Given this list of marker genes CR2, MGAT2, CD79B, MEIS2, IL7R, BLNK, RAG1, SLC39A7 (NCBI Gene Id 7922), ARPC5, CHD7, POLE, ACP5, IL2RG, CD3G, LAT, LRBA, SMARCAL1, BRAF, RTEL1, ADA, HBB, MAGT1, IKZF1, MBTPS2, MLPH, RNF31, IFNGR1, TBX1, FCGR3A, MTHFD1 (NCBI Gene Id 4522), PSMB10, PRKDC, RBCK1 (NCBI Gene Id 10616), PGM3, CTPS1, TICAM1, CTC1, FGFRL1, PTEN, PRPS1, GATA2, POGZ, BUB1B, ICOS, TNFRSF4, IRF7, HIRA, IL2RB, PIK3CA, TERC, RNF168, TP53, SKIC3, HYOU1, CD3E, SLC46A1, UNC119 (unc-119 lipid binding chaperone), SDHC, SH2D1A, TNFRSF1B, TYMS, SPI1, IRF2BP2, PIK3R1, DNMT3B, USB1, RAG2, MCM10, LRRC8A (leucine rich repeat containing 8 VRAC subunit A), OTULIN, SEC23B, EPG5, IKBKB, TINF2, CD79A, MS4A1, IGHM, TLR3, USP8, TBCE, CD19, LAMTOR2, WIPF1, IL2RA, CYBB, CD28, RREB1, TRAF3, NHEJ1, TCF3, CDCA7, UHRF1, STAT1, ORAI1, TNFRSF13C, PSTPIP1, CYBA, STK4, ATM, STIM1, LCP2, MAPK1, IFNGR2, MYC, ZBTB24, SP110, PI4KA, BCR, SBDS, SKIC2, NFE2L2, IL12B, CRKL, JMJD1C (jumonji domain containing 1C), DPP9, TYK2, HELLS, DKC1, RAB27A, CD81, DOCK2, ACD, ANTXR2, WRAP53, CDC42, LCK, AMN, IGLL1, SIK3, CUBN, DNAJC21, ADA2, CD40LG, CACNA1C, IVNS1ABP, ACTB, NFKB2, TNFRSF13B, IRF8, MALT1, CCDC47, CDH23 (NCBI Gene Id 7395), SLC19A1, CD3D, XRCC4, NPM1, SEC24C, WAS, JAK3, AKT1, CREBBP, XIAP, SDHB, EXTL3, CTLA4, CORO1A, NOP10, LIG4, EFL1, RMRP, UNC93B1, NCF1, LMNB2, FRAS1 (Fraser extracellular matrix complex subunit 1), FOXN1, AFG2A, NHP2 (NCBI Gene Id 55651), NCF2, CPLX1, RAC2, CTBP1, AK2, SDHD, ATRX, DIAPH1, IKBKG, TERT, CD247, KLLN, TBK1, EP300, BCL11B, GP1BB, CUL4B, NR3C1, AGL, IRAK4 (NCBI Gene Id 95458), AP3D1, COMT, AICDA (NCBI Gene Id 57379), IL12RB1, MMUT, KNSTRN, ISG15 (ISG15 ubiquitin like modifier), PIK3CD, PNP, LYST, NSD2 (nuclear receptor binding SET domain protein 2), ARVCF, ALG1, LETM1, ZNF699, USF3 (NCBI Gene Id 205717), CARD11, USP48, TTC7A, TFRC, PARN, BCL10, DCLRE1C, ICOSLG, UFD1, DCLRE1B, UNG, BTK, POLD3, CARD9, IL21R, MAN2B1, CHD1, NFKB1, TNFSF12, CD40, here is a description of the gene set: Immunodeficiency species: Homo sapiens Failure of the immune system to protect the body adequately from infection, due to the absence or insufficiency of some component process or substance. Human Gene Set: HP_IMMUNODEFICIENCY